The following is a description of a gene set: studied in species Homo sapiens Human Gene Set: chr4p12, and this is the list of marker genes: COMMD8, NFXL1, MIR8053, TXK (NCBI Gene Id 7294), ENSG00000282904, CNGA1, RNU6-931P, RNU6-412P, RPL15P7, GNPDA2, PRDX4P1, GABRA2, GUF1, ATP10D, GABRA4, CORIN, RNU6-838P, YIPF7, ENSG00000295039, RN7SKP199, RPL21P52, GABRG1, THAP12P9, RAC1P2, GABRB1, COX7B2, NIPAL1